The following is a description of a gene set: Genes predicted to be targets of miRBase v22 microRNA hsa-miR-632 in miRDB v6.0 with MirTarget v4 prediction scores > 80 (high confidence targets). Human Gene Set: MIR632 from publication Chen Y, Wang X (PMID 31504780) species: Homo sapiens, and this is the list of marker genes: CHST3, ITGBL1, SIX3, NTM (NCBI Gene Id 50863), UBE2Q2, SELENOK, IKZF3, NRARP, CASP14, TAF6, SUCO, ROR1, RNF125, MEF2C, RASA1, ZNF45, BCL11A, ADAM10, SMR3B (NCBI Gene Id 10879), HOXC4, AP1G1, FBXW11, EPB41L1, CD40LG, ELF3, CC2D1A, TANK, ZNF552, AMELX, KCMF1, SHISA7, ZEB2 (zinc finger E-box binding homeobox 2), LHPP, ZFC3H1, NBPF9, ING3, UHRF1, LRRC4C, UIMC1, GPRIN3, IFT57, CAPZB, BMAL1, KLF4, SAXO1 (stabilizer of axonemal microtubules 1), MBNL1, RUVBL1, LAPTM4B, TRMT13, USPL1, UGT8 (NCBI Gene Id 7368), COLEC12, SERTAD2, SPRYD7, KIF1B, ZC3HAV1, PSIP1, FAR2, TOMM6, LIN9, SNRK